The following is a description of a gene set: Genes having at least one occurrence of the motif NNNTGAGTCAKCN in the regions spanning 4 kb centered on their transcription starting sites. This matches the JUN transcription factor binding site V$AP1_01 (v7.4 TRANSFAC). studied in species Homo sapiens Human Gene Set: AP1_01, and this is the list of marker genes: CHST4, PCDH17, SLC38A2, DTNA, VCL, MAPK10, BTK, ARHGAP8, NECAB3, POLR1G, GFAP, BUD31, EXD1, EPHX4, SKIDA1, DUSP14, KRT8, SERPINB5, LENEP, LNX1, CALB2, FGF12, AQP5, HEPH, PSMD2, DTX2, ABCD1, PPP2R2C, C9orf85, RTL9, MIR22HG, IVL, BNIP3, TUBA4A, COL7A1, GADD45G (growth arrest and DNA damage inducible gamma), RUNDC3A, PSMD7, SLC26A1, PLEKHH3, NDP, MAP2, ABCB6, MYOZ2, SMPX, LRP1B, COL27A1, ELAVL2, CDK14, SH3RF2, GTF2B, BAZ2A, TIAL1, PADI4, ROM1, TEX19, SSH2, ULK1, ALDOA, FBRS, ABCA2, LAMA3, TINAGL1, ZNF516-DT, RBBP7, FOSL1, G3BP1, SLC22A18AS, TRIB1, IDS, ATP1B1, EWSR1, MYB, WDR81, PEA15, MAPRE3 (microtubule associated protein RP/EB family member 3), CA9, LUC7L, MAP4, SNCB, PSMD11, DIRAS1, MDFI, RIT1 (NCBI Gene Id 6016), ABHD4, CLRN1, ABI3, TLL1, RGS8, GPSM3, ALS2CL, SLC38A3, RAP1GAP2, ZNF771, DMD, KBTBD8, GADD45A, TNRC6A, STX17, BAG2, TCF7 (transcription factor 7), ATP6V1C2, SFTPC, KCNA2, DYNC1H1, HDAC3, SYNGR1 (NCBI Gene Id 9145), CSF3, EPHA2, SLC35E4, NRIP3 (nuclear receptor interacting protein 3), RABGAP1L, TRAF3, EYA1, TMCC1 (transmembrane and coiled-coil domain family 1), DPH1, UBALD1, SHC3, DHRS3, SLC22A18, PHLDA2, RAB3D, UBXN10, HBEGF, MMP7, NLK, CLIC1, DUSP13B, VAPA, SPRED1, MSI1, TBXAS1, PPP2R5B, TENT5B, LRRFIP2, RBP4, CILK1, AKT3, GNGT2, GDNF, LY6D, RELL2, SERTAD1, CPNE8, TNFRSF12A, TUBB4A, CHP1, IL6, ABHD17B, ANXA7, HSD3B7, NCDN, OMG, MIDEAS, TGFBR2, BACH1, YWHAG, HS3ST2 (NCBI Gene Id 9956), KCNK10, P2RX6, SEPTIN9, STRADB (STE20 related adaptor beta), GABARAPL1, EEF1A2, ENO1, FGF9, CPA6, EIF3J, XIRP1, IL11, S100A2, SCUBE3, CYTOR, DCTN2, ANGPT1, SEPTIN4, HSPB8, SLC25A51, LINC02908, USP13, WASF2, RMDN2, OLR1, CTTNBP2NL, ST18, VDR, MARK1, CMAS, SQSTM1, ATP6V0D2, CDH23 (NCBI Gene Id 7395), POLD4, PTPRN, ABCF3, PTPRR, PLCD1, TUBA4B, AKIRIN2, GPAT3, FAM184A, ITGAX, PRPF38B, IRAK1, TRPV3, SLC4A11, SNCG, NUDT10, PIM1 (NCBI Gene Id 82453), SV2B, SNX10, DLX1, APOBEC1, LINC02694, VASP, ADRA1A, LMNA, SLURP1, MRGPRF, PPP1R9B, CSMD3, IGSF9, CYRIA, PSMD12 (NCBI Gene Id 5718), LAMC1, SCEL, PLBD2, SMARCA2, ZFAND5, RB1CC1, RHBDD3, BICDL1, SYT2, COQ8B, HSPA9, CRACDL, TAGLN2, CCDC50, MECP2, NPFFR1, C19orf33, SLC11A1, ZPBP2, MAPK12, ASB5, ATXN7L2, PSMA3, VAT1, CDKN1A, PLEC, PVALB, COL5A3, REXO2, EMP3 (epithelial membrane protein 3 (MAM blood group)), HS6ST2, MMRN2, NEK6, RIN1, NEDD4L, RNF34, TNXB, C1orf220, ANKRD28, HCN3, PPP2CA, NUDT11, GSTP1, CCL27, RPS20, EEF1A1, SPATS2, TAC1